The following is a description of a gene set: Binding to a nuclear vitamin D receptor, a nuclear receptor that mediates the action of vitamin D by binding DNA and controlling the transcription of hormone-sensitive genes. species: Homo sapiens Human Gene Set: GOMF_NUCLEAR_VITAMIN_D_RECEPTOR_BINDING, and this is the list of marker genes: MED1, MED4, TAF11 (NCBI Gene Id 6882), MED12, SNW1, MED17, THRAP3, TOB2, MED16, TAF7, MED24, MED14, MED13, RXRA, MED30